Given this list of marker genes TBCE, CYP27B1, GNAS, STX16, FAM111A, CLDN16, CYP2R1, PTH, GATA3, VDR, GCM2, TNFRSF11A, here is a description of the gene set: studied in species Homo sapiens Hypocalcemic seizures Human Gene Set: HP_HYPOCALCEMIC_SEIZURES